The following is a description of a gene set: Mouse Gene Set: GOBP_VASCULAR_ENDOTHELIAL_GROWTH_FACTOR_SIGNALING_PATHWAY The series of molecular signals initiated by vascular endothelial growth factor (VEGF) binding its receptor on the surface of the target cell, and ending with the regulation of a downstream cellular process, e.g. transcription. species: Mus musculus, and this is the list of marker genes: Il12a, Pdgfra, Hrg, Tcf4, Epha7, Tie1, Itga5, Ephb2, Il12b, Epha5, Cadm4, Pik3cd, Tek, Myo1c, Epha1, Epha8, Tyro3, Tspan32, Pik3ca, Foxc1, Ephb1, Ros1, Epha10, Vegfb, Smoc2, Igf1r, Epha3, Adamts3, Ephb4, Musk, Ptp4a3, Dab2ip, Nrp1, Ddr2, Met, Insrr, Insr, Vegfa, Pik3cb, Epha6, Fgfr1, Ntrk3, Ltk, Dll1, Robo1, Xdh, Vtn, Sema6a, Dcn, Ror2, Flt4, Ddr1, Adgra2, Erbb4, Flt3, Pdgfrb, Epha2, Itgb1, Vegfc, Pgf, Adgrg1 (adhesion G protein-coupled receptor G1), Spry2 (NCBI Gene Id 24064), Epha4, Csf1r, Rela, Mst1r, Emilin1, Ntrk2, Vegfd, Cd63, Kdr, Alk, Ccbe1, Mertk, Flt1, Fgfr2, Ntrk1, Fgfr4, Fgfr3 (fibroblast growth factor receptor 3), Jcad, Kit, Ephb3, Gab1, Nrp2, Nus1, Egfr, Erbb2, Axl, Ret, Itgb3